The following is a description of a gene set: studied in species Homo sapiens part of: Plasma lipoprotein assembly Reactome Pathway: VLDL assembly Very low-density lipoprotein (VLDL) is synthesised in the liver in two steps. First, apolipoprotein B-100 (APOB-100) is co- and post-translationally lipidated in the rough ER lumen. After transfer to the smooth ER lumen, lipidated APOB-100 acquires lipids to become bona fide VLDL. Lipid composition of VLDL - triglycerides (50-60%), cholesterol (10-12%), cholesterol esters (4-6%), phospholipids (18-20%), and apolipoprotein B (8-12%). When VLDL assembly is complete, it travels along the Golgi apparatus to be eventually secreted from the liver into general circulation. In circulation, VLDL can acquire more lipoproteins. At least two other apolipoproteins are constituents; apolipoprotein C-I (APOC1, around 20%) and apolipoprotein C4 (APOC4, minor amount)., and this is the list of marker genes: MTTP, APOC4, APOC1, APOB, P4HB